The following is a description of a gene set: The transformation of benign lesions to malignant tumours is a crucial aspect of understanding chondrosarcomas, which are malignant cartilage tumours that could develop from benign chondroid lesions. However, the process of malignant transformation for chondroid lesions remains poorly understood, and no reliable markers are available to aid clinical decision-making. To address this issue, we conducted a study analysing 11 primary cartilage tumours and controls using single-cell RNA sequencing. By creating a single-cell atlas, we were able to identify the role of endoplasmic reticulum (ER) stress in the malignant transformation of conventional central chondrosarcomas (CCCS). Our research revealed that lower levels of ER stress promote chondrosarcoma growth in a patient-derived xenograft mouse model, while intensive ER stress reduces primary chondrosarcoma cell viability. Furthermore, we discovered that the NF-?B pathway alleviates ER stress-induced apoptosis during chondrosarcoma progression. Our single-cell signatures and large public data support the use of key ER stress regulators, such as DNA Damage Inducible Transcript 3 (DDIT3; also known as CHOP), as malignant markers for overall patient survival. Ultimately, our study highlights the significant role that ER stress plays in the malignant transformation of cartilaginous tumours and provides a valuable resource for future diagnostic markers and therapeutic strategies. Present primarily in benign and low-grade tumours (Ben, Low_1, and Low_2). osStro cells expressed ossification and hypertrophic chondrocyte related genes MMP13, KLF10, ENPP1, as well as COLIAI/Collagen I Human Gene Set: SU_HO_CONV_CENT_CHONDROSARCOMA_STROMAL_C1_OSSIFICATION_STROMAL_CELL from publication Su Z, Ho JWK, Yau RCH, Lam YL, Shek TWH, Yeung MCF, Chen H, Oreffo ROC, Cheah KSE, Cheung KSC (PMID 38267611) studied in species Homo sapiens, and this is the list of marker genes: CTNNB1, ANKH (ANKH inorganic pyrophosphate transport regulator), CTTN, ZBTB16, SOX4, YWHAQ, FGFR2, TMEM14A, AOPEP, CDC42SE1, EIF4G2, NR4A1, IFNGR1, FHL1, PRKAR1A, HSPH1, ARF6, TM9SF2, HNRNPA0, CCND2, OAT, LAMP1, NDFIP1, DLX5, FOSB, ANKRD35, UBE2E3, PDCD4, HIF1A, RASL11B, TIMP3, SPPL2A, DSTN, HAPLN3, FN1, CHMP1B, B4GALT1, SARAF, MORF4L1, MEAF6, MMP13, RGS16, ENPP1, NT5DC2, CLMP, TRPS1, HSP90AA1, ATG101, GPAA1, TGIF1, MAF, RTN4, MMP3, MAFB, SRSF3, TMEM98, AP2M1, NFIL3, EZR, DDX5, OAZ1, KLF5, DSEL (dermatan sulfate epimerase like), SLC38A2, COQ10B, OTUD1, UBE2Q2, EGR2, CNIH1, PRDX1, NUDT4, JUN, SERTAD4, SCARA3, SRSF6, HNRNPAB, PIM1, SLC20A1, SLC40A1, FKBP5, JMJD1C, ATP1B3, PABPC1, RCAN1, MORF4L2, SRSF2, SERTAD1, GLUL, TSPYL1, PYURF, SDC2, SDC4, PDLIM5, DNAJB6, ABL2, ANKRD28, SSPN, FAM107B (family with sequence similarity 107 member B), MIDEAS, CMPK1, F3, SOD2, DNAJB4, FOXO3, SMOC1, PTTG1IP, EIF3E, LMO4, LRP10, SRSF5, FOXC2, DNAJA1, TMCO3, CBFB, FBLN7, HSPD1, KLF10, SBDS, GABARAPL2, LBH, YBX3, FOXC1, UAP1, AK1, STRAP, MCL1, ANXA5, SELENOS, LUZP1, SLC29A1, ID4, FDX1, H3-3A, SCP2, PPP1R15A, FGFR1, ITPRIP, ST3GAL4, CD276, UQCC5, NDUFB1, MIR222HG, HSPE1, ABHD2, CD47, EXTL2, NFATC2, IRF1, IRF2BP2, ZFP36L2, RIN2, CCT6A, NEDD9, CAPG, TUBA1B, TACSTD2, YWHAZ, TPBG, PELI1 (NCBI Gene Id 57334), NFKBIA, GADD45G, CD164, IVNS1ABP, NAA50, CDKN1A, PPP3CA, SFPQ, CDC42, INTS6 (NCBI Gene Id 26512), CLU, ZFAND5, C1orf56, CSRNP1, HSPA8, FNDC4, NUCB1, ID2 (NCBI Gene Id 3398), HNRNPM, KLF9, MIR22HG, BGLAP, TNFRSF18, CYB5R3, TLE4, PPP1CB, RASD1, SRPX, PLA2G2A, ISLR, ATP6AP2, ITGA10, KLF2, TMED2, GYPC, CEBPB